Given this list of marker genes IKBKG, EDA, TBX3, ZMPSTE24, KDF1 (NCBI Gene Id 126695), LMNA, NFKBIA (NCBI Gene Id 4792), NTRK1, here is a description of the gene set: Absence or developmental hypoplasia of the sweat glands. Aplasia/Hypoplasia of the sweat glands studied in species Homo sapiens Human Gene Set: HP_APLASIA_HYPOPLASIA_OF_THE_SWEAT_GLANDS